The following is a description of a gene set: Mouse Gene Set: GOCC_ARP2_3_PROTEIN_COMPLEX A stable protein complex that contains two actin-related proteins, Arp2 and Arp3, and five novel proteins (ARPC1-5), and functions in the nucleation of branched actin filaments. species: Mus musculus, and this is the list of marker genes: Actr2, Arpc2, Arpc3, Arpc1a, Arpc4, Arpc1b, Arpc5 (actin related protein 2/3 complex, subunit 5), Arpc5l, Actr3